The following is a description of a gene set: part of: Signaling by Hedgehog studied in species Mus musculus This event has been computationally inferred from an event that has been demonstrated in another species.<p>The inference is based on the homology mapping from PANTHER. Briefly, reactions for which all involved PhysicalEntities (in input, output and catalyst) have a mapped orthologue/paralogue (for complexes at least 75% of components must have a mapping) are inferred to the other species. Reactome Pathway: Hedgehog 'on' state electronically inferred by orthology from the curated human pathway, and this is the list of marker genes: Gpr161, Arrb2, Shh, Psmd1, Cdon, Psmd13, Psmb4, Psmb6, Psmd6, Psmd7, Psmd12, Psmc6, Smurf1, Psmb5, Psmc1, Psma7, Smo, Smurf2, Csnk1a1, Ubb, Psma4, Psmc5, Psmb7, Gli3, Psma1, Psma3, Evc, Psmc3, Gas1, Psmc2, Rps27a, Numb, Ihh, Psma6, Psma2 (proteasome subunit alpha 2), Evc2, Ulk3, Psma5, Psmc4, Spop